The following is a description of a gene set: Mouse Gene Set: REACTOME_AQUAPORIN_MEDIATED_TRANSPORT studied in species Mus musculus Aquaporin-mediated transport, and this is the list of marker genes: Aqp2, Gnas, Myo5b, Rab11fip2, Prkacb, Aqp12, Gngt2, Gnb1, Gnb5, Rab11a, Gnb2, Gng2, Aqp5, Gng8, Gng5, Gng3, Aqp7, Avpr2, Gng13, Gng7, Avp, Gngt1, Aqp9, Prkaca, Gng4, Aqp1, Prkar1b, Aqp8, Prkar1a, Gng12, Gng10, Aqp3, Gnb4, Aqp4, Gnb3, Aqp11, Mip, Gng11